The following is a description of a gene set: from publication Yevshin I, Sharipov R, Kolmykov S, Kondrakhin Y, Kolpakov F (PMID 30445619) Genes containing one or more binding sites for (PAX3) in their promoter regions (TSS -1000,+100 bp) as identified by GTRD version 20.06 ChIP-seq harmonization. species: Homo sapiens Human Gene Set: PAX3_TARGET_GENES, and this is the list of marker genes: JMJD1C, PEX14, DMXL2, RAB30, RNU7-35P, EI24, RPL7P41, ENSG00000250781, MTUS1, CCIN, CNOT2, TTC8, LINC02818, NRDC, GSE1, PCNX4-DT (PCNX4 divergent transcript), ZNF540, MMP20, OMA1, PEAK1, ENSG00000240291, MGST1, RN7SKP76, PRKG2-AS1, SLC37A4, STAU1, SDHC, AATF, COA1, SLC3A1, FOXN3, KTN1, MAP2K5, PPM1B, FBXL17, RPP40P2, PPM1N, CYRIB, DOCK2, DHDDS, CCDC81, LINC00320, WWC2, SP110, EMCN, LIN54, SENP6, NEK3, SLC35D2, TRAPPC9, EPM2A-DT (EPM2A divergent transcript), KIR3DX1, RN7SKP141, MARCHF10, RPL36AP20, XYLT1, HDAC2-AS2 (NCBI Gene Id 107986638), PIAS1, AGO2, PCDHGB9P, LINC02832, CLYBL, LINC02960 (long intergenic non-protein coding RNA 2960), CSN1S2AP, KIDINS220, ANKRD6, HAS3, GRIN2B, ADAM28, SLC25A13, ASMTL, HMGB1P24, C11orf42, TMPO, CCDC122, FBXO34, TTC13, DNAJC24, RNA5SP430, LARGE1 (LARGE xylosyl- and glucuronyltransferase 1), LRIT3, ENSG00000236106, VGLL4, CTAGE11P, CCNE1, PROS1, GLT8D2, SYNE1, ADARB2, MIR135A2, CNTLN, CACTIN, PROX1-AS1, DHRSX, LCP2, TRIP12, PCDH17, CDYL, BBX, CDH2, LINC03007, PTGER2 (NCBI Gene Id 63381), FASTK, KHDRBS3, EPDR1, RNU6-727P, ENSG00000258525, RAD9B (RAD9 checkpoint clamp component B), OR2A14, MFSD12, MYO1D (myosin ID), COQ4, GTF2IRD1P1, LINC00919, PHF14, RASSF1, TNKS, COQ2, CHD7, TPD52, MYOM2, CNNM2 (NCBI Gene Id 54805), RASA2, UBA1, STRC, TJP1, HGD, UST, VCX3B, EPS8, NUP205, TES, SIAE, CCDC192, LBR, C2orf92, NEXN-AS1, MIR6133, ARHGEF26-AS1, RPS26P15, CHN2, C5orf58, SAP18P3, OACYLP (O-acyltransferase like, pseudogene), MCTP2, KMT2A, ARID1A, UGT2B7, LINC02895, SLAIN2, RNU6-531P (RNA, U6 small nuclear 531, pseudogene), PTTG1IP, USP47, RPS6, TENM3, CDON, FABP7P1 (NCBI Gene Id 100506953), SLC17A5, DSCAML1, MRM3, SPATS2L, CAAP1, CLDN18, SHQ1, RASAL2 (NCBI Gene Id 9462), MIR634, RNU6-475P, MZT2A, ITFG2-AS1, TAFA2, STARD6, SOX5, CYP39A1, FAM135B, NTAN1, GNRH1, KPNA2P2, TBC1D14, DNAJB6, CD86, HMGN2P47, HNRNPR, RPL32P12, ANAPC15, KIF15, GEMIN8, FMR1, MSRB3, LIPH, MIR2681, GABRR1, WDR4, PIK3R4, GTF2H4, RSU1P3, SNAP23, MIR4529, ZFAND6, ARHGAP10, H4C8, SSC5D, PHF5AP4, LINC00598, MARK3, SCML4, RNU4-1, PEX5L, SYNPR, CHD6, OSTF1, CYP20A1, ANKRD12, AHSA2P, USP50, TRAJ21, POFUT2, MTCO3P7, TBC1D4, SSBP3, DECR1, EGLN3, SORT1, ENSG00000274385, PHOX2B, SS18, FAM13C (NCBI Gene Id 220965), NEB, SUGT1, POGLUT3, FAM13A, TRAJ38, ZNF23, ANKS1B, RN7SKP61, RPS27P21, EIF4H, ZDHHC17, CD4, RNA5SP135, PRCP, RPS15AP18, B4GAT1-DT, KHSRP, NR2E1, DNAJC5G, ARMH3, STX8, MIER1, ADK, ARPC2, LTBP1, BLTP1, CTTNBP2, IMMP1L, ENSG00000268129, ADGRF4, TBXAS1, JKAMP, RPS4XP16, ACTN2, NR1H2, CFAP20, TRAPPC12, CFTR, TAF15, MAST4-AS1, RBM48, TCF4, DDX10, TLE6, NAF1, RPL21P11, SMG7, SPAG9, BAALC, RNVU1-14, POU2F1, MIR498, DPP4, LINC00216, SCAF1, LINC02923, NEK7, FAM168A, LGALS3BP, RNU6-1066P, PPFIA2, FAAHP1, SEC11C (SEC11 homolog C, signal peptidase complex subunit), CRISP3, ARSL, TRUB2, GALNT13, ATG12, DAAM1, IQCH, TFDP3, RNU6-628P, AHCTF1 (AT-hook containing transcription factor 1), LINC02534, HS2ST1, RAF1, POLA1 (NCBI Gene Id 5422), RNU6-1338P, ZNF891, PTP4A1, MIR1251, GCG, URI1 (NCBI Gene Id 8725), LINC00355, DOCK4, LINC02336, KCNH5, MSL2, MDN1-AS1, MIR6129 (microRNA 6129), SEMA3A, RPL17, HCG15, HPRT1P1, OPCML, KCTD1 (potassium channel tetramerization domain containing 1), FAF2P1, ATXN7, CH25H, MIPEPP2, INSC, NR2F1-AS1, CHMP1B-AS1, SOX9-AS1, IPP, PLCB1, LINC01058, POC1A, GAS6, BCAS2P2, GREB1L, AKAP9, MRPS31, KCNMB3, CWC27, RSBN1, MTCYBP3, LINC00958, GALNT7, LIMCH1, HCG25, WNK1, CCDC159, DLGAP2, FRMD6, REXO2, SNORD114-13, LINC02700, DNAJB1, MYO1E, HMOX2, GLS, UBE2I (ubiquitin conjugating enzyme E2 I), RPL36AP54, CREB5, TARID, SASH1 (SAM and SH3 domain containing 1), ANKRD10, NIPAL2, METRNL, TBC1D23 (TBC1 domain family member 23), LINC01591, EHBP1, DCP1B, HTR3B, KDSR, MIR133A1HG (MIR133A1 host gene), ENSG00000255605, RPS17P13, CPNE6, GSTCD, AKAP1, ZBED3-AS1, NDUFS1, TMEM131, PABPC1, CYTH3, BPNT1, RNF130, TXNDC5, BACE2, RNU6-784P, HTR2A, FBN2, RPL31P38, CCSER2 (NCBI Gene Id 54462), SH2D4A, SNX8, MC2R, FRMD5, RNU6-821P, NDUFV2, PTPRM, HBP1, EIF4BP6, BMX, RNU6-1190P, MIR223HG, DPYD-AS2, ZKSCAN1, ZNF131, CLK4, RIF1, SNORD113-9, PLEKHF2 (pleckstrin homology and FYVE domain containing 2), IGF2BP3, NIBAN3, XBP1, HMGB1P32, LINC01141, ADGRD1, EBLN1, RPS15AP6, YWHAZ, ANKHD1, INTS6-AS1, BPIFB2, CLUAP1, WDR17, EPHA4, RNU6-1152P, FBXO36, RN7SKP100, IMPA2, MIR3171, PPIAP16, DLG2, RPL21P104, ALB, NXN, TMEM168, CNIH4, TRBV22-1, CPLX4, KDM5C, MTATP6P7, FNDC3B, ZNF169, INTS7, AFP, CSTF1, LRBA, SIAH1, RPS7, ZDHHC13, CTIF, TMEM161B-DT, UBR5, CFHR3, RNU6-457P, CTNNB1, ALDH1A2, CENPJ (centromere protein J), EPRS1, MTHFD2P3, RNU6-253P, SLC8A1-AS1, TTC41P, MTATP6P23, IGSF9B, RPL29P22, TMEM19, NSF, TRPM3, RPL7AP48, NATP, MIR3650, NEO1, NFRKB, LNCPOIR, GMDS, ROBO2, TRAJ35, RNU2-12P, ARIH1, UBE4B, EPHA7, SNX2, SELL, SLC25A5P9, ASAP1, RPL17P49, RTN2, MICAL1, LINC02521, LINC00626, SEPTIN11, DNAAF11, TENM2, MIR297, ZNF830 (zinc finger protein 830), MEF2C-AS1, COPS5P1, GRAMD2B, ATG5, TRAV11, LINC00578, RPL36P15, TG, MTCO1P15, GABPB1-AS1, RNU6-324P, G2E3, NRXN1, RPSAP70, LINC02763, RNU6-107P, ACACA, CHORDC1P4 (CHORDC1 pseudogene 4), WDR7, MIR4634, RNU6-1244P, MIR9-2HG, PTPRB, FBXW7, RNU6-259P, TRAF3IP1, NKTR, HMGB1, KCNMB2, DDX5, FERMT3, PIPOX, MYO1H, MAPK4, GSPT1, RPL37, ENSG00000255357, CYP19A1, PPP2R5C, ATP2A2, ARSB, BRD2, SMARCD2, CRYZL1, RBMS1, LINC03000, OR6C74, SNORD104, SMARCAL1, SUSD1, RNU6-912P, MOCS2, ENTPD1, RBM46, TRMT9B, KRBOX1-AS1 (KRBOX1 antisense RNA 1), ARFGAP3, TTC4, SF3B6 (splicing factor 3b subunit 6), TRAJ37, SCAT8, NACA4P, AP2B1, CSDE1, ARHGEF28, GPATCH4, OTUD7B (NCBI Gene Id 56957, OTU deubiquitinase 7B), GAS2, DBP, SH3TC2, ZNF490, INSIG2, INKA2, SLC9A2, ATP6V1D (ATPase H+ transporting V1 subunit D), LIPJ, FAP, USP3, TBC1D19, C3orf38, ZNF714, PTP4A2, MIR302D, GBE1, SESTD1, BTLA, FHL2, TMTC2, SGIP1, PNPLA6, DCC, MRPS23, PDLIM5, FLVCR1, CLCN3, PTPN13, CCT6B, KIZ, PDCD11, SLC5A10, RNU11, LINC02548, ECT2L, CYCSP24, AUTS2 (NCBI Gene Id 26053), HECTD1, LGALSL, SESN1, ARMH4, EYS, SLC7A5P2, LINC01708, IDO1, NFIA, LIFR, F2RL2, RANBP2, LINC01495, ZNF207, FHIP1B, APBB2, OSBPL8, PIGS, NUDT15, MTBP, PEF1-AS1, ALKBH3, UPF1, SRR, RN7SL735P, WBP2, B4GAT1, SMG1P3, CUEDC1, LRRK1 (leucine rich repeat kinase 1), LINC02055, LINC01905, CSMD3, PHF19, LINC02518, LINC02289, CSTPP1, OSMR-DT, ZNHIT3, LINC01435, MCTP1, DOCK8-AS2, CYP1B1-AS1, LINC02387, LGI1, CDCA2, PACSIN2, KCNMA1-AS1, LINC01828, TIMM8BP1, CPNE4, ARHGAP28, FOXJ3, MIR4501, CAPN7, TAS2R7, OSR1, HNRNPA3 (heterogeneous nuclear ribonucleoprotein A3), TTC28, RASSF5, SVBP, AAAS, CRPPA, LINC01116, EEF1A1P42, FBXL14, TMEM177, WASHC2C, FAM169A, AIDAP2, PSMA7, PNLDC1, LEF1-AS1, DLGAP1, TARS2, ENOX1 (ecto-NOX disulfide-thiol exchanger 1), STIL, ANTXR2, GORAB (golgin, RAB6 interacting), SATB1-AS1, THBS4, RAB3C (NCBI Gene Id 115827), GBP7 (guanylate binding protein 7), LARP7, LINC00709, RNY4P17, CRADD, IL16 (NCBI Gene Id 3603), SLC44A1, SNORD73A, STARD13, NSRP1, RRAS2P2, ESR1, PPP1CC, SLC5A12, RPS26P29, LINC01020, RPS12P16, SETD5 (NCBI Gene Id 55209), GRWD1, RPS15AP3, TRAPPC3, EGFEM1P, PRKAG2, LINC00665, FAR1, GOLGA1, TMEM205, NPM1P2, RNU6-469P, DEPDC5, PBRM1, ZNRF3, TMEM270, PDK1, GPR141, LPP, NAA15, MIR548AL, DNAJC21, MCC, FAM245A, ARPP21, BTNL2, MIR367, FRG2MP, ITIH4 (inter-alpha-trypsin inhibitor heavy chain 4), RELCH, PTBP2, ERC1, MIR3169, RPL36AP17, MMACHC, RNA5SP269, RRBP1P2, CXXC5, PRTFDC1, OR6C70, LINC03014, GALNT11, MIR4759, DPH5-DT, TMEM41B, RSRC1, VSIG1, ENPP6, MGMT, VPS13D, ERBIN, RPS27P6, MTND5P19, ARFIP1, LINC02669, RN7SKP253, OTUD4, ATP6V0D2, BIRC6, MTND2P19, LINC00310, PKM, KIAA0513, TXNDC2, FAM114A2, GAS7, CDH13, PGM2L1 (NCBI Gene Id 283209), DDC, LINC01239, TAF2, MIR99AHG, LINC02650, NKAIN2, B3GLCT, GIN1, ALDH1A3-AS1, RPS6KA5, SNORD58A, FTO, MYO1A, APOO, OR52D1, ATP6V1B2, PNN, MIR4742, LMO3, WDR7-OT1, TACSTD2, PKN3 (NCBI Gene Id 29941), RSPRY1, CLN3, RNA5SP118, SEMA6A, HSDL2-AS1, CHRM3, HMGCS1, STRN4, PTPN4, LINC01574, GNPTAB, TNFRSF10B, CYB5AP5, GAS2L3, LMO1, DCX, LINC02553, CHUK, KIAA1217, PRDM6, MIR7-3, LINC00645, GCNT3, SNAI2, LINC01829, SUN1, DCUN1D5 (defective in cullin neddylation 1 domain containing 5), PSMB4, PHACTR2, KCNMA1, RNU6-365P, ENSG00000199894 (NCBI Gene Id 124900892), MIS18BP1, CAMTA1 (NCBI Gene Id 23261), BIRC3, PSMD14, MIR646HG, EEF1A1P25, RNU6-130P, METTL17, COL15A1, ARHGAP15, CRIPTO3, HNRNPU, SERPINB7, ATP9B, SOX9, LIPM, MGC27382, RN7SL216P, MUSTN1, PIAS2, MAST4, ERMARD, ANKRD44, SLIT3-AS1, METTL9, DCBLD2, LINC00710 (NCBI Gene Id 254312), SEC14L1, ZFR, SRSF9, SDC2, ENSG00000231460, EXPH5 (NCBI Gene Id 23086), ANKAR, PWRN1, CTNNA3, KLF5, TRMT12, PIEZO2, AHR, PSMA6P3, ZDHHC2 (zinc finger DHHC-type palmitoyltransferase 2), RNU6ATAC6P, GTPBP8, MYO1B, TYRP1, GLOD4, RNU6-178P, DYNLRB1, DCUN1D2 (NCBI Gene Id 56234), FBXO38, ZFPM2, C18orf54, MIR4279, RBM39, KCNK9 (NCBI Gene Id 51305), SCUBE1, RAC1P6, ATG14, KLHL7, UTS2B, POU6F2, NSMAF, USPL1, PTPRG-AS1 (NCBI Gene Id 100506994), SEC1P (NCBI Gene Id 653898), H2BC15, MIR802, CLEC1B, GANC, ARNT, RPA1, MTND2P5, ZFP30, ZNF80 (NCBI Gene Id 7634), DNAJB4, OR52A4P, TLE4, LRP8, PUM2, ENSG00000201733, ZCCHC8, SMPD4BP, ENSA, TUBB4BP1, PDP1, TRIOBP, DTNA (dystrobrevin alpha), FBXO11, TBCA, CLIC5, RNU4-26P, USP34, UBE2CP2, DRGX, NAV3, SDCBP, QPCT, ENAH, CCDST, UBIAD1, PCNX2, RCOR3, RPS27P10, USP28, VPS35, ITFG1, SEC24D (NCBI Gene Id 9871), DENND4A, P2RX6, GNAL, NDEL1, RPS29P21, RPS6KB2, LINC02493, GIP, GRM8, BFSP1, SNX24, CELF2, DICER1, COX6B1P4, RPL7P49, NSUN6, DGKI, RNU6-271P, AIG1P1, TRIM37, PAQR9-AS1, TMEM209, TMED3, SPIRE1, SPPL2B, CALCOCO1, CD47, CD300LD-AS1, ULK4 (NCBI Gene Id 92216), TRIP4, TSPAN9, AOPEP, ALDH3A2, ATOSA, CFAP126, RNY4P34, RPL32P9, MAGI1, TRAPPC3L, MALSU1, FARSB, BRCA2, TSPAN8, DNM3, SKINT1L, ATP5MK, UNC79, PCNX1, ABRACL, RNU6-1137P, TAPT1, RNU6-588P, NBAT1, GK3, LINC02670, MFAP3, SCYL2, UBN1, STT3A, PRDX2P1, LINC01470, WDHD1, TARS3, LINC02134, FRG1-DT, MGC32805, SLC12A1, FLNB, LINC00844, UBE2E3, PRMT9, CTR9, DUXAP11, KIF1B, GOLGA4-AS1, HSD17B2, RNF34, ATP6V0A4, SOCS4, GDF15, AK4P6, MAP4K3, RPL38, ERGIC2, CFAP299, SPRED2, KANK1, ATP6V1C1, PKIB, LINC02632, CMPK2, DARS1-AS1, SLC1A3, EPB41L3, DYM, LINC01589, NFE2L3, GRK4, DNAI4, CAMTA1-DT, RABGAP1, H4C1, HAPLN1, RNA5SP23, RNU4-46P, SYNE1-AS1, RN7SKP40, ATP10D, RPL27, TBC1D31, ANAPC5, ZNF385D-AS2, KATNAL1, KDM2A, MYL6P3, A3GALT2, ERMAP, FKBP14-AS1, LDB2, ENSG00000257279, POU6F2-AS2, GLYATL1, GASK1B-AS1, UCHL1-DT, MIR3973, IL5RA, LINC00972, AOAH, C12orf60, TRPM8, SGCE, IGFBPL1, CEMIP2, ZBTB2, DKK2, PGM5, ENSG00000249695, SCIN, TCF12, HUS1, LRRC8B, MIR100HG, LINC01082, ASB9, LINC01533, HELQ, GLI3, SEM1, CNTRL, UTP3, RPSAP24, SNHG25, SUMO2P16, ALG10, RNU105B, NR3C1, TFAP2A, TCTN1, NUF2, BSPRY, DCUN1D4, RNU6-558P, TTI2, CCNL1, MTND6P14, BHMT, MTND6P33, KPNB1, ABT1P1, FBXO34-AS1, SPAG6, INSL6, FAM114A1, ACP3, CALM1, CDKL3, PCLAF, NAALAD2, USP48 (ubiquitin specific peptidase 48), TTC21B, CCDC186, ALKBH5, DPY19L4P2, RAB3D, LINC02389, POLDIP3, RNA5SP31, LINC01415, KMT2C, CFAP91, GPR161, CENPU, CA5BP1, ENSG00000202537, SMIM30, MIR1322 (NCBI Gene Id 100302166), LINC01849, REST, TGFBR3, MIR548F2, RESF1, ZGRF1, SEMA3C, OR2AD1P, CORO1C, DIAPH3, TERF1, GABRA1, ENSG00000249690, RNU6-554P, PCNX4, MTREX, MIPOL1, ERC2, LINC01584, ANKHD1-DT, MS4A1, ZEB2, ZZEF1, USP6NL, LBX1-AS1, MFSD1, POLR1F, PPIG, MTCO1P18, CDK4P1, PALLD, PCGF6, NAE1, POLD3, TMEM191A, BTF3, CEP57, PDPK1, PPP1CB, LINC03116, MUC15, SMARCA2, PARP8, FGF10, WARS1, CLCN3P1 (NCBI Gene Id 100419056), PRKCH, FCRLA, HHIP, RPS2P55, PTPN12, EPHA2, SNORD127 (NCBI Gene Id 100113389), UBR3, MTCO1P9, ENSG00000204684, MTF2, NLGN4X, PPP6R3, MARCHF4, SETD6, KLHL23, RPSAP26, ARHGEF10, TUT1, MDN1, MRI1, RPL7P14, ARHGAP19, BPIFB9P, LINC01883, LINC02779, NRG4 (NCBI Gene Id 145957), PAK3 (NCBI Gene Id 5063), MPP7, LINC02513, ATM (NCBI Gene Id 8068), KPNA4, PRKCE, HSD17B4, RNU4-18P, CERS5, CCDC59, MIR5188, SLC47A1P2, SEZ6L-AS1 (SEZ6L antisense RNA 1), ODF1, NDUFV2-AS1, RNU1-139P, ANXA5, PYROXD1, CA5B, MTCO1P23, INTS5, TRIT1, GK, PPP2R1A, FNBP4, NMRAL1, CDK1, LRRC27 (NCBI Gene Id 92295), LINC01151, ENSG00000233393, KCTD9, RPL5P8, SNORD73B, FEZ2, RBBP6, MOCS2-DT, NFIB, TXNDC11, ZAR1L, APC, LINC00347 (NCBI Gene Id 338864), HES3, LINC01798, INTS6, TRMT1, VAPA, EVI5, MRPS27, CHMP1B, DIS3L, MBIP, FBXO38-DT, SLC12A8, MTATP6P20 (NCBI Gene Id 107075201), IPCEF1, C14orf39, RBM47, MIR320C1, PABPC4L, TBCK, CCDC175, LINC02350, ZNF429, PHLPP1, SLC15A5, RNU6-667P, PIGA, IFNNP1, MYO3B-AS1, TM9SF3, SLC25A51, RNU6-340P, COL6A3, ADD1, RFC1 (NCBI Gene Id 5981), LINC00431, ITGA6, KRT223P, PSMD1, IFNG-AS1, ZNF781, AFF1, GTF3C3, SH3D19, CYB5R4, RNF217, ENSG00000257176, N4BP2L2, DOK5, MIR3685, KLRC1, ZBTB38, ADNP, SHC2, SLC25A31, CDH8, DPP9, CHRM3-AS2, ENSG00000275443, ENSG00000222095, BCAS3, RNU4-15P, ZFP91-CNTF, TLCD4, KDM1A, AZIN1, CLC, ANO3, XPO5, VTCN1, MPL, SHOC1, SECISBP2L, C6orf52, MRPS18C (mitochondrial ribosomal protein S18C), SMARCC2, LINC00607, TECR, UGT1A2P (NCBI Gene Id 54580), IL33, RGS5, SPEF2, LINC01572, HEXB, HLA-DMA, HIVEP1, SLC15A4, FRG1, CCDC6, EIF3F, SF1-DT, SLC7A5P1, ARID1B, XPNPEP1, BRPF1, SUV39H2, PDE9A-AS1, VCP, CREB1, OR5AK4P, KRTAP21-2, BANP, RPL7L1P17, SPP1, RNA5SP137, NAPEPLD, ZC2HC1B, H2BC1, NDP-AS1, DNM2, ZNF775, ANGPT1, CNOT1, GCC2, LINC02092, ZBTB20, RPL23P6, KCNN2, AGAP3, ENSG00000266100, SCGB2B2, LINC02944, SPDL1, PIP4P2, ATP10B, SLC14A2-AS1, GULOP, ANKRD60, IL7, ITGB1 (integrin subunit beta 1), ART3, ENSG00000179066, TMBIM6, ACSL5, SCARNA5 (NCBI Gene Id 677775), GNA12, TMEM260, RNU6-197P, ELP2, SMG1, POLR2CP1, SRP68, SND1-DT, PARN, PSMB1, RALGPS2, MIR548A3, SNORD13, SLX4IP, GPR15, NDUFA9, C8orf76, CHSY1, ITFG2, CLEC2D, HNRNPD, TRIO, EFR3A, MET, RPL7P28, MMP2, GATB, RAB11A, DLEU1, FENDRR, PSMG2, IL13RA2, TAF1D, TTBK2-AS1, RORA-AS1, LINC00652, ZNF385B, MUC7, STX18-AS1, ENSG00000232995, COL28A1, RPS10P9, SEC13, GIPC2, DNAH9, LINC01877, COBLL1, DDX12B, MYBL1, SMARCE1, TMEM52B, FLAD1, TRAJ34, LINC03088, ENSG00000233178, CCDC162P, WWTR1-AS1, MUSK, GSDME (gasdermin E), CITED2, ENSG00000227157, SUPT4H1, METTL25, LAMB1, CASC18, TRAK2, HDAC9, MTND2P20, RNU12, TCTN3, ODF2, L3HYPDH, SLIT2, TAX1BP1, MIR378E, OLFM3 (olfactomedin 3), MIR218-1, AK4P5, RNU6-203P, PSMD14-DT, BACH2, F8, MATR3, FRG2LP, KANSL1L-AS1, RNU6-884P, SNX19, PSKH2, THUMPD3, UBR4, MIR3692, MACROH2A1, MRPL30, STX5, HOXB-AS1, MPV17L2, ARHGAP21, TLR10, MTFR1, RMST, VLDLR, SHC4, MEIS2, SRGAP3, TIAM2, DDX52, INTS10, FARS2-AS1, IQCK, BRCA1, SAFB2, NEDD4L, NHP2, SETDB2, LINC02532, RNU6-579P, DLGAP4-AS1, CXCL10, DEFB109F, BZW1, UGT1A4, MIR548H4, C12orf76, RNU7-104P, RPSAP67, GNPNAT1, GNG2, HMGB2 (high mobility group box 2), ZNF106, STX16, NEXN, PIGW, CPB1 (NCBI Gene Id 1360), FOXP1, SNORD81, SNHG22, CLTC, RNU6-341P, NHLRC1, GCLC, STX18, UGT1A1, STX5-DT, FAM228B, SPTBN1, SS18L1, TLN2, AP3S1, HSPB3, TNIK, ZRANB2-DT, CAPN2, RPL30P14, HSP90B1, PDE4D, NGF, RPL7AP36, RACGAP1, PCBP3, PTS, OPA1, DMRTA2, SNTG1, ENSG00000227101, AURKA, TEX56P, RNU6-173P, SKAP2, DHPS, MDGA2, TIAM1, FARP1, RNU6-1039P, SRSF1, U2SURP, RNU6-442P, AOX2P, LAMA3, RN7SKP13, FABP5P7 (fatty acid binding protein 5 pseudogene 7), SNX9, UBC, ANKHD1-EIF4EBP3, AGR2, ADAMTS10 (NCBI Gene Id 81794), LINC01140 (NCBI Gene Id 339524), NELL1, MIR4642, RIMS1, LDHC, RAD51B, RNA5SP222, STRBP, LINC02073, EBAG9, NIPA2P4, EEF1AKMT2, ZBTB41, NDUFB5, ZNF10, VAV3, FN1, DNAJB12 (NCBI Gene Id 54788), CACNA1G (calcium voltage-gated channel subunit alpha1 G), SIMC1, SHB, GALNTL5, SORBS2, POF1B, DKK1, RALGPS2-AS1, FRMD4B, CDH12, HK3, MIR7-3HG, HMGCL, FXR1, LIPG, HTR2B, RN7SL446P, RRN3P3, ARPP21-AS1, DENND3 (DENN domain containing 3), ERVK13-1, MAPK10, MIR4452, CUL3, TIGAR (NCBI Gene Id 57199), TNK1, LINC01122, KDM4C, MIR6885, LINC01739 (long intergenic non-protein coding RNA 1739), RNA5SP154, ADGRL2, LINC00570, CHD9, MIR4466, SPINK1, CHP1, DENND2B, RN7SL60P, LINC01892, GAK, RNU6-1102P, SSTR5-AS1, ACAD10, ASPH, ZNF219, LRCH3, HSPA8P16, YWHAH-AS1, SLC7A8, MIR4799, NLGN1, SSTR5, TDRG1, CSN1S1, ESAM, SLC10A6, ETFBKMT, KIAA1143, CLPB, ODAD2, SMG7-AS1, LINC00470, PPFIBP1, DNM3OS, MTCO1P47, EID1, RAPGEF5, KAZN, ADAM1B, XPOTP1, YPEL5, INPP4B, RPS27P13, USP15, LINC00364, WSCD1, SYNE2, FOCAD, HNRNPC, CCDC141, NAV2-AS4, ATP11A, PPFIA1, ENSG00000270174, LINC00240, CAB39L, USP33 (ubiquitin specific peptidase 33), WBP11, DPYS, TXNRD2, SEL1L, TBX15, AP2M1, LINC02338, PPIP5K2, LNX1, ATP1A1-AS1, FYN, LINC02031, TRIM43CP, LAMC1, MACO1, ITCH, MAP4K4, DAG1, RAB5CP2, CFAP97P1, SALL4, PRTG, GGA3, TPBG, RNA5SP447, LINC01074 (NCBI Gene Id 106144607), TRAJ20, SLC39A11, DCTN1, CNN3-DT, NDUFV3, PDZPH1P, LIMA1, RPL10AP3, DOCK11, LIPN, TFAP2D (NCBI Gene Id 83741), NFU1, C1orf141, GDE1, FGF7, GEN1, TBC1D2B, RUFY3, LINC01206, MVB12B, S100G, PGM3, LINC01846 (long intergenic non-protein coding RNA 1846), TOR1AIP1, PEX5L-AS1, ZNF16, LINC01438, DENND5A, ENSG00000253557, NT5DC2, MARF1, MIR548BB, ALMS1-IT1, SLC9A4, CLASP2, LINC02212, RAI14, DMD, SF1, LINC01545, DYNC2I2, OR5V1, POR, LCDR, NVL, NRG3, RPS12P5, NELL2, SLC16A6P1, H2AC1, MYCBP2, KIF21A, ZNF217 (NCBI Gene Id 7764), TMEM246-AS1, NMU, LINC01355, ASAH1, UCHL1, NUP93, TOR1AIP2, RPL36P14, ELOBP4, NT5C3A, EXOSC10-AS1, ELL2, GPC6-AS1 (GPC6 antisense RNA 1), AKR1B1P4, LINC01966, FRRS1, FABP5, GFER, WLS, GOLGA7, RPL22, FCHSD2, ZNF791, CLEC9A, LPP-AS1, KANSL1L (KAT8 regulatory NSL complex subunit 1 like), ADGRE4P, WDR74, ELP4, SNORA50C, CDIP1, UST-AS1, USP6NL-AS1, SNRPE, STRN3, PATJ, ALG14, AKTIP, CDK12, FUBP1, FAM21FP, MIR4527HG, RRAS2, ATG16L1, IPO11, PKN1, CTSA, ASS1, LGSN, KDM4B, MYOCD-AS1, VARS2, FOXP2, MYO9A, ENSG00000232058, C6orf89, TMA16P1, JAZF1, VPS29, WDR86-AS1, NDRG1, SLMAP, FUZ, HOXB2, TECPR2, MIR155HG, AMZ2P1, LINC01111 (long intergenic non-protein coding RNA 1111), FOXK2, RNU7-153P, RNU6-397P, ECT2, DST, GORASP2, ZNF571, PIK3CB, MIR3659, LDHA, SKP2, DYRK4 (dual specificity tyrosine phosphorylation regulated kinase 4), NIN, C11orf54, JAG1, UHRF2, LINC01309, ELAVL2, ZNF639, RPL7AP51, SVOPL, COX16, PRELID3BP4, TRPS1-AS1, CDH20, NRIP1, PPIAP43